The following is a description of a gene set: species: Homo sapiens Neighborhood of PTPRD protein tyrosine phosphatase, receptor type, D in the GCM expression compendium Neighborhood of PTPRD Human Gene Set: GCM_PTPRD, and this is the list of marker genes: FADS1, ZFP14, ZNF565, PTK2, FRYL, ACER3, RASSF3, PREPL, MOAP1, MAP4K4, NAA30, BACE1, FBXW11, ACTRT1, KIF1B, TTL, TAFA5, NIPA1, ULK2, UBE2H, TTYH2, ZEB2, SIK3, RALGAPA1, HERC2, RABEP1, MARF1, ABI2, FAM219A, DNAJB14, ABHD6, LANCL1, DOCK9, CCDC88A, POMT2, SCARB2, GPRC5B, BTRC, NDRG3, NLK, PKP4, MAP1B, TRIM8, PTPRD, SPIRE1, SLAIN1, ANKRD17, CLASP2 (cytoplasmic linker associated protein 2), PEG3 (NCBI Gene Id 5178), ZNF536 (zinc finger protein 536), PHYHIPL, BLTP1, ANKS1B, CIPC, PLEKHA1, ARPP19, MEGF9, GZF1